Given this list of marker genes Th, Slc6a3, Moxd1, Snca, Gch1, Ddc, Dbh, Atp7a, Nr4a2, Tgfb2, Kl, Gpr37, Aldh2, Cyp2d22, Epas1, Crhr2, Hand2, Pnmt, Park7, Vps35, Gata3, Dao, Agtr1a (NCBI Gene Id 72294), Agtr2, Insm1, Hdc, Moxd2, here is a description of the gene set: Mouse Gene Set: GOBP_CATECHOL_CONTAINING_COMPOUND_BIOSYNTHETIC_PROCESS The chemical reactions and pathways resulting in the formation of catechol-containing compounds. Catechol is a compound containing a pyrocatechol nucleus or substituent. species: Mus musculus